The following is a description of a gene set: studied in species Mus musculus Mouse Gene Set: MIR_7036B_3P from publication Chen Y, Wang X (PMID 31504780) Genes predicted to be targets of miRBase v22 microRNA mmu_miR_7036b_3p in miRDB v6.0 with MirTarget v4 prediction scores > 80 (high confidence targets)., and this is the list of marker genes: Brsk2, Tmem260, Nfx1 (NCBI Gene Id 93788), Gm5916, Csnk1g1 (NCBI Gene Id 71616), Zfp207, Dok3 (NCBI Gene Id 27261), Ankrd13a, Gapvd1, Fam20b, Zfp644, Armh1, Irf6, Tnfsf13b, Tia1, Fcrla, Ptprk, Ankrd46, Lamc1, Acvrl1 (activin A receptor, type II-like 1), Ifi213, Zfp704, Brca1, Dennd10, Lpcat3, Helb, Galnt3, Mast4, Plet1, Amer2, Med14, Gramd1c (GRAM domain containing 1C), Hycc2, Astn1, Echdc3, Lingo1, Tmem119, Xpr1, Cux1, Nmt1, Rnf145, Col6a5, Sned1, Acvr2a, E130308A19Rik, Katnbl1, Rbms3, Coro2a, Smchd1, Mcu, Slc2a3, Adprm, 1700025G04Rik, Desi2, Dab2, Spout1, Hnrnpc, Elavl2, Marchf6, Chrm1, Pip4k2b, Fgfr2, Ube2n, Plekhm3, Slc22a15, Slc39a14, Arhgap12, Nefl, Zfp128, Nfib, Aldh3a2, Tpt1, Dlx4, Kctd6, Loxl3, Pakap, Eif2s3y, 2510039O18Rik, Rpp14, Bmf, Irs1, Cnr2, Syndig1l, Tmem252, Xxylt1, Plcg1, Erfe, Mtf1, Cmbl, Pate5, Ebp, Slamf6, Cenpi, Ilf3, Spred1, Mink1